The following is a description of a gene set: Genes predicted to be targets of miRBase v22 microRNA hsa-miR-665 in miRDB v6.0 with MirTarget v4 prediction scores > 80 (high confidence targets). from publication Chen Y, Wang X (PMID 31504780) species: Homo sapiens Human Gene Set: MIR665, and this is the list of marker genes: NIPBL, UNC119B, TRIM66, SCAI, GLYAT, TENM3, FBXO41, ALKBH5, DOK6, ZER1, TBC1D13, PKNOX2, SPCS2, TXNL1, PSMF1, ARHGEF5, CA13, RIMS4, KIF21B, SMUG1, ADPRHL1, HEYL, ABCC3, UNC5B, HOXB6, RASGEF1B, SSR2, ACOT2, MAP3K8, DNAJC13, DEPDC5, COA8, JPH1, FCRL5, NDOR1, TGFBR1, ATP2A3, MLLT1, TRAPPC9, FABP2, CHKB, HNRNPH3, UBE2Q1, SLC46A1, BATF2, SLC7A14 (solute carrier family 7 member 14), TMEM104, CD276, ILF2, DERL3, COPS7B, RAP1GAP2, GRAMD4, TTLL11, RPAP1, ACOT1, CYTH3, CD200R1, ONECUT2, GDAP1L1, LUZP1, HABP4 (hyaluronan binding protein 4), ARMC10, ZCCHC2, SLC25A35, CHST3, MAPK8IP2, ARRB1, MARCHF8, IRF4, MINAR1, ANKRD13C, TRIM8, MLF2, LASP1, SCUBE3, ZNF609, CCDC57 (coiled-coil domain containing 57), SF3B3, RNF24, MOB3A, MLLT6, NLK, UPP2, CARNMT1, CASTOR3P, DUX4, CARHSP1, IGFN1, DNAJB1, PFKFB2, SLC4A8, USP49, STAT2, PLA2G2F, PPARA, ASB13, SUMO1, NAA40, SV2C, DDX3X, TGFBR2, MTMR4, PRR14L, ALG8, COL3A1, SMAD7, CLLU1-AS1, SLC37A3, OR9Q1, TIMP3, WDR48, RGL3, ATP8A2, SHLD2, APBB2, C19orf47, DLX3, HOXB5 (homeobox B5), STK35, SCAMP5, KDR, TET2, MAGI1, CFAP53, KCNN3, TP53I11, SLC25A28, GFI1B, LINC02873, STX3, POU2F1